Given this list of marker genes D2hgdh, Usp53, Gdap2, Ccdc88c, Ifi202b, Tchh, 4833420G17Rik, Ivd, Cldn8, Ppip5k1, Hspa1a, Tmem267, Lrig3, Hal, Tubgcp4 (tubulin, gamma complex component 4), Plet1, Mtrex, Neto2, Scart1, ENSMUSG00000137801, Ralgps2, Sgk1, Rccd1, H3f3b, Nfe2l2, Fkbp5, Ythdc2, Rnf187, Sult1c2, Sfrp1, Stox2, Ttr, Jmjd7, Haus2 (HAUS augmin-like complex, subunit 2), Per1, Fubp1, 1810012K16Rik, Gm37254, Dnaja4, Ppfibp1, Hspa4l, Ighg2c, P4ha1, Camk2d, Smim10l1, Ccdc32, Hspa1b, Slc22a15, 3110040N11Rik (RIKEN cDNA 3110040N11 gene), Cap1, St6galnac1, Satb2, Snhg14, Arsk, Slc15a2, Pdk4, Mcc, Afg2b, Thoc1, Ighm, Oip5, Lncppara, Zfp266, Niban3, Ppargc1a (NCBI Gene Id 320239), Dhrs1, Gm10503 (NCBI Gene Id 100038436), Ramac, Vcam1 (vascular cell adhesion molecule 1), Pot1b, Hoxb5os (homeobox B5 and homeobox B6, opposite strand, NCBI Gene Id 75395), Vps39, Rgs5, Tmem242, Nup62, Gip, here is a description of the gene set: Mouse Gene Set: CADWELL_ATG16L1_TARGETS_DN Genes down-regulated in Paneth cell (part of intestiinal epithelium) of mice with hypomorphic (reduced function) form of ATG16L1. species: Mus musculus Susceptibility to Crohn's disease, a complex inflammatory disease involving the small intestine, is controlled by over 30 loci. One Crohn's disease risk allele is in ATG16L1, a gene homologous to the essential yeast autophagy gene ATG16 (ref. 2). It is not known how ATG16L1 or autophagy contributes to intestinal biology or Crohn's disease pathogenesis. To address these questions, we generated and characterized mice that are hypomorphic for ATG16L1 protein expression, and validated conclusions on the basis of studies in these mice by analysing intestinal tissues that we collected from Crohn's disease patients carrying the Crohn's disease risk allele of ATG16L1. Here we show that ATG16L1 is a bona fide autophagy protein. Within the ileal epithelium, both ATG16L1 and a second essential autophagy protein ATG5 are selectively important for the biology of the Paneth cell, a specialized epithelial cell that functions in part by secretion of granule contents containing antimicrobial peptides and other proteins that alter the intestinal environment. ATG16L1- and ATG5-deficient Paneth cells exhibited notable abnormalities in the granule exocytosis pathway. In addition, transcriptional analysis revealed an unexpected gain of function specific to ATG16L1-deficient Paneth cells including increased expression of genes involved in peroxisome proliferator-activated receptor (PPAR) signalling and lipid metabolism, of acute phase reactants and of two adipocytokines, leptin and adiponectin, known to directly influence intestinal injury responses. Importantly, Crohn's disease patients homozygous for the ATG16L1 Crohn's disease risk allele displayed Paneth cell granule abnormalities similar to those observed in autophagy-protein-deficient mice and expressed increased levels of leptin protein. Thus, ATG16L1, and probably the process of autophagy, have a role within the intestinal epithelium of mice and Crohn's disease patients by selective effects on the cell biology and specialized regulatory properties of Paneth cells. from publication Cadwell K, Liu JY, Brown SL, Miyoshi H, Loh J, Lennerz JK, Kishi C, Kc W, Carrero JA, Hunt S, Stone CD, Brunt EM, Xavier RJ, Sleckman BP, Li E, Mizushima N, Stappenbeck TS, Virgin HW 4th (PMID 18849966)